The following is a description of a gene set: The regulated exocytosis of secretory granules containing preformed mediators such as histamine and serotonin by a platelet. studied in species Mus musculus Mouse Gene Set: GOBP_PLATELET_DEGRANULATION, and this is the list of marker genes: Tph1, Lyn, P2rx1, Stxbp1, Plek, Syk, Fcer1g